The following is a description of a gene set: Binding to a ribosome. species: Homo sapiens Human Gene Set: GOMF_RIBOSOME_BINDING, and this is the list of marker genes: PTCD3, EIF2S1, SBDS, LARP1, ABCF1, DHX29, USP16, GTPBP6, CPEB2 (cytoplasmic polyadenylation element binding protein 2), ETF1, MAIP1, TACO1, NMD3, HSPA5, MCTS1, NOMO3, EIF3K, EIF4H, MRRF, CPEB3, SEC61G, DHX33, EEF2, MTRES1, EFL1, PIM1, YTHDF1 (NCBI Gene Id 54915, YTH N6-methyladenosine RNA binding protein F1), NDUFAB1, DDX3X, CCDC47, IGHMBP2, UNG (NCBI Gene Id 7374), ANG, TMEM223, NAA15, IMPACT, TTC5, EIF2A, ZNF598, MTOR, PELO, SLFN12, SHFL, NEMF, NOMO2, CPSF6, DNAJC2, YTHDF3, SLFN14, MTIF3, EIF6, SRP72, ZC3H12A, SERBP1, EIF1B, CPEB4, EIF3C, NCLN, MAP3K20, CPEB1, SEC61B, TMCO1, OLA1 (NCBI Gene Id 89690), RPSA, MIURF, DHX9 (DExH-box helicase 9), RICTOR, EIF1, ABCE1, UCHL1, METTL17, G3BP1, NME1, TMEM147, LTN1, LETM1 (NCBI Gene Id 3954), SEC61A1, ERI1, MTRFR, BAG6, EIF5A2, EIF4B, HABP4, PYM1, C1QBP, LETMD1, NOMO1, DAP, ERAL1, SRP68, UQCC5, RACK1, FMR1, GUF1, STAU2, GEMIN5, UNK, SRP19, IFRD2, DAPL1, RBM3, NPM1, EIF5A, EIF5AL1, MALSU1, SEC61A2, MTIF2, NAA10, LETM2, OXA1L, MPV17L2, NAA16